The following is a description of a gene set: species: Homo sapiens Human Gene Set: GSE10240_IL22_VS_IL22_AND_IL17_STIM_PRIMARY_BRONCHIAL_EPITHELIAL_CELLS_UP Genes up-regulated in primary bronchial epithelial cells stimulated with: IL22 versus IL17A and IL22. from publication Aujla SJ, Chan YR, Zheng M, Fei M, Askew DJ, Pociask DA, Reinhart TA, McAllister F, Edeal J, Gaus K, Husain S, Kreindler JL, Dubin PJ, Pilewski JM, Myerburg MM, Mason CA, Iwakura Y, Kolls JK (PMID 18264110) Primary HBE cells were stimulated with IL-22 and IL-17, and gene expression was studied using an Affymetrix platform microarray, in order to investigate which genes may be upregulated or downregulated in response to these cytokines. Of particular interest was the host defense genes such as antimicrobial peptides, which have been shown to be upregulated by IL-22 and IL-17 in skin keratinocytes., and this is the list of marker genes: PDCD11, NUP35, ECEL1, NEAT1, AP4B1, DFFA, PRKAB1, GALNT10, CYTH4, ATOX1, IRF6, SNUPN, CD200R1, HOMER1, THADA, HSPH1, TNFAIP8L1, AKNA, KLRG1, LRRC8C, SELPLG, MEA1, MAF1, IL2RA, ENPP1, PLEKHM1 (pleckstrin homology and RUN domain containing M1), SNRNP27, COQ10B, KRI1, DDIT4, TRAF2, SLC35D2, TRAPPC3, SOSTDC1, ARF5, B4GALNT1, LMBRD1, FAM219B (NCBI Gene Id 57184), SLC11A2, IL4, CLYBL, CEP350, ARHGEF4, ERO1B (endoplasmic reticulum oxidoreductase 1 beta), FXYD5 (NCBI Gene Id 53827), TSPYL4, SGMS1, APBA3, SMIM11, TIMM10B, VIRMA, C8orf58, ABCB1, RAB20, IER3IP1, ALDOA, USP34, CD8B, EIF5A2, FOXN3, RGS11, FAM210B, CYBB, FASTKD2, FEZ2 (fasciculation and elongation protein zeta 2), TTC39B, RINL, CERS4, SPO11, CD6, TNFRSF4, TMEM120A, MIA3, ESYT1, CCDC88B, MRPL33, PPME1, DDC, SLC46A3, PAK2, ARID5B, PRDM1, ECM1, MBOAT1, ZNF524, COX16, ARHGAP29, CNR2, GZMK, RUNDC1, FAAH, BTBD6, INPP4B, GPSM3, SDF4, NRBP1 (NCBI Gene Id 29959), CAP2, MRTFA, INTS15, DHRS13, XRN1, HLA-DRB1, FAAP20, GPR68, SIDT2 (NCBI Gene Id 51092), ADD1 (NCBI Gene Id 118), CCDC82 (coiled-coil domain containing 82), LCN8, LGALS3, HERC3, EPAS1, BACH2, UBASH3A, RGS3, ORMDL3, RFXANK, ST8SIA6, GDAP2, XDH, LGMN, KIF1B, TIMP2, ZFPM1, CHD7, RNF5, WSB2, TAPBP, CSNK1G2, CCNK, DAPK3, PPP1R15A, RAB4B, CRIM1, SMURF1, GALNT12, ZBTB37, SLC12A7, NDUFA3, TOX2, ZW10, SPIB, H1-4, AAK1, CDR2, SMURF2, ATP5F1D, NAPRT, TXNRD2, ZMAT5, CCDC30, C22orf39, AP3M2, TYK2, IL27RA, CD3E, TUFM, S100A4, DAPL1, CTSW, FLOT2, GPR107, JUNB, TRADD, GLCCI1, BATF, NT5E, RAPGEF4, SDCBP2, GCC1, BAX, ISG20, CLDN10, CCR6, TRIP4, ALG1, PLBD1, GAB3, PHC3, SC5D, SCAMP3, NIPAL1, BORCS6, ZCCHC17 (NCBI Gene Id 95373), TRPM1, JMJD7-PLA2G4B, FAM149B1, ENC1, PACC1, DGAT1, CFLAR, BCL6, TRPC4AP, AVEN, VPS37B, SLC25A24, ZC3HAV1, ATG16L2, SLA2, DBNL, RELA